Given this list of marker genes Npc1, Fut9, St6gal2, Man2c1 (mannosidase, alpha, class 2C, member 1), St6galnac6, Mogs, St6galnac5, St8sia1, Neu2, Treh, St6galnac3 (ST6 (alpha-N-acetyl-neuraminyl-2,3-beta-galactosyl-1,3)-N-acetylgalactosaminide alpha-2,6-sialyltransferase 3), B3galnt1, St3gal4, Neu4, St8sia3, Manba, Fut1, St8sia4, Sis (sucrase isomaltase), Neu3, St8sia2, Lalba, Neu1, B4galt1, Hexb, Fut2 (NCBI Gene Id 14344), St3gal2, Sec1, St6galnac4, Naga, St6galnac1, Man2b2, B3galt1, B3galt2, Lct, St8sia5, Mpdu1, Mgat2, Gm2a, Ctbs, Gla, Mgam, Abo, Man2b1, Fut4, St8sia6, here is a description of the gene set: The chemical reactions and pathways involving oligosaccharides, molecules with between two and (about) 20 monosaccharide residues connected by glycosidic linkages. Mouse Gene Set: GOBP_OLIGOSACCHARIDE_METABOLIC_PROCESS species: Mus musculus